The following is a description of a gene set: Mouse Gene Set: CUI_CDC1_IL7_RESPONSE_DN studied in species Mus musculus from publication Cui A, Huang T, Li S, Ma A, Pérez JL, Sander C, Keskin DB, Wu CJ, Fraenkel E, Hacohen N (PMID 38057668) Genes negatively differentially expressed in cell type: cDC1 (conventional dendritic cell type 1) upon treatment with cytokine: IL-7 in mouse lymph nodes in vivo. Cytokines mediate cell-cell communication in the immune system and represent important therapeutic targets. A myriad of studies have highlighted their central role in immune function, yet we lack a global view of the cellular responses of each immune cell type to each cytokine. To address this gap, the authors created the Immune Dictionary, a compendium of single-cell transcriptomic profiles of more than 17 immune cell types in response to each of 86 cytokines (>1,400 cytokine-cell type combinations) in mouse lymph nodes in vivo. A cytokine-centric view of the dictionary revealed that most cytokines induce highly cell-type-specific responses. For example, the inflammatory cytokine interleukin-1β induces distinct gene programmes in almost every cell type. A cell-type-centric view of the dictionary identified more than 66 cytokine-driven cellular polarization states across immune cell types, including previously uncharacterized states such as an interleukin-18-induced polyfunctional natural killer cell state., and this is the list of marker genes: Kctd12, Rgs2, Txnip, Hspa1b, Hepacam2, Gdi2 (GDP dissociation inhibitor 2), Bmyc, Ccr2, Inpp5d, Mef2c, Arhgap45, Tsc22d3, Arhgap5, Pold4, Pid1, Cytip, Klhl24, Npm1, Rsrp1, Klf2, Hspa1a, Pdcd4